The following is a description of a gene set: Mouse Gene Set: ZKSCAN1_TARGET_GENES Genes containing one or more binding sites for (Zkscan1) in their promoter regions (TSS -1000,+100 bp) as identified by GTRD version 20.06 ChIP-seq harmonization. species: Mus musculus from publication Yevshin I, Sharipov R, Kolmykov S, Kondrakhin Y, Kolpakov F (PMID 30445619), and this is the list of marker genes: Cd84, Tsen15, Ly6g, Avil, Fdx2, Slc6a7, Gm26440, Dmtn, Fmnl1, Sema4a, Chmp2a, Lyrm9, Pdzd2, Arl10, Sec22b, Gm7538, Eif4a2, Cog7, Ctnnb1, Slc6a9, Vsir, Bbc3, Slc25a36, Adgrd2-ps, Ubc, Rhod, Adgrl2, Cd300c, Gm31373, Utp14a, Hdac7, Gna15, Cdk2ap1, Kmt2a, Rapgef3, Cilk1, Hspe1, Abhd2, Myo10 (myosin X), Derl3, Ctu2, Zfp579, Ube2f, Ddx39a, Phc1 (polyhomeotic 1), Exoc2, 0610012D04Rik, Aldoa, 3110083C13Rik, Tnfsf12, A430005L14Rik, Tnnt1, Sergef, Atxn2, Ythdf2, Myo15b, Trim14, Zfp458, Dhrs7, Snx12, Arhgap27os1, Tmem25, Nfxl1, Gm19710, Cops8, Frat1, Armt1 (acidic residue methyltransferase 1), Ddx51, Zfp438, Nr1d1, Jup, A930001C03Rik, Ssbp1, Tnpo2, Zfp518a, Cdca5, Cnst, Ap5s1, Tmem63b, Mlip, Psmc1, Adamtsl5, Macroh2a1, Sh3bp1, Ncor2, Plscr1l1, Gm17786, Zfp444, Tmem229b, Ccdc97, Sh3bgrl, Gnb2, Idh2, Ggt1, Cfap97d1, Zfp58, C920009B18Rik, Stab1, Sdf4, Cltc, Nceh1, Vps16, Syde2, Klf1, Ube2l3, Gpam, 2010320O07Rik, Mef2a, Rmnd1, Ibtk, Glo1, Gm12279, Gm24195, Alg9, Psme1, AW495222, Nfatc2, Etv6, Gm10778, Gpr182, Rnf166, Tpcn1, Hif3a, Zbtb7a, Slc25a20, Cldn10, Zdhhc5, Dok2, Tgif2, Pten, Stx6, Yipf1, Phip, Tmem9b, Glud1, Zc3h6, Zan, Ssrp1, Ubb (NCBI Gene Id 22187), Zfp87, Adam22, Slc2a9, Cwc15, Cytip, Bmf, Tomt, Hoxd3, Ccdc88a, 2810013P06Rik, Rpl9, Kit (KIT proto-oncogene receptor tyrosine kinase), Slc19a3, Igf2bp1, Strn4, Sycp2l, Sat1 (NCBI Gene Id 20229), Cd74 (CD74 antigen (invariant polypeptide of major histocompatibility complex, class II antigen-associated)), Ecel1, Noc4l, Mark2, Ralgapb (NCBI Gene Id 99013), Zmynd19, Rfx2, Dnajc15, Gm5960, Ptpn3, Slu7, Spag6 (NCBI Gene Id 381350), Asb1, Wtap, Ino80dos, Tnfsfm13, Ahi1, Otogl, Calm3, Stmp1, Gm17023, Tmem176b, Gm5447, Nr2f1, Scly, Defb30, Unc5b, Chid1, Pms1, Kctd17, Lgals1, Brap, Lias, Kdm5b, Gnat2, Prdm15, Haus5, 4933426K07Rik, Elmo2, Ppp2r3a, Nat10 (NCBI Gene Id 98956), Or2t26, Epn1, Rhbdf1, Irak4, A830082K12Rik, Tram1, Slc41a2 (NCBI Gene Id 338365), Ccng2, Hspd1 (heat shock protein 1 (chaperonin)), Med6, Bahd1, Ogt, Rrp36, Arid1b, Mpz, Iqcf4 (IQ motif containing F4), Ppil4, Gm11523, Gm11175, Unc13a, Slc19a1, Rptor, Mir1932, AU041133, Lypla2, Mrpl27 (mitochondrial ribosomal protein L27), Ugt1a7c, Scp2, Klhdc8b, Noa1, Elavl1, Son, Siae, Mrpl10, Thumpd3, Gnai2, Gm13025, Fscn1, Cd164, Pkp1, Synrg, Kpna3, Tmem176a, Ccn5, Stimate, Necap2, Arhgef6, Ing3, Acot8, Rasgrp4, S1pr2, Mprip, Cttnbp2 (cortactin binding protein 2), 1700029M20Rik, Zfp236, Mcur1, Qsox2, Mia2, Ubr3, Hpdl, 1700020N01Rik, Fnta, Wdtc1, Atg2a, Gm10863, 1810019N24Rik, Lpin1, Sumf2, Susd1, Gigyf2, Cmtm4, Mbtps2, Tpm2, Ncln, Ccdc71, Hax1, Kcnn4, Ak3, Ginm1, Spcs2, Tmco4, Arhgap18 (NCBI Gene Id 73910), Grm2, Bicdl2, Tmem42, Rusc2, Paip1, D8Ertd738e, Plekha7, Rap1a, Emc7, Nhlrc3, Lama4 (laminin, alpha 4), Smurf2, Zfpl1, Mir3089, Rpl41, Gm8790 (NCBI Gene Id 667745), Gm10524, Tbl1xr1, Ccl22, Sh3glb1, Pttg1 (pituitary tumor-transforming gene 1), Slc22a18, Adamts10, Zfp282, Ulk2, Fgd3, Rhof, Dnal4, Tomm20, Adnp, Ly6c2, Zfp513, Dnajc21, Slc2a6, Pbk, Magoh, Ing4, Tatdn2, Itpripl2, Map2k3 (NCBI Gene Id 26397), Gab2, Kri1, Serpinc1, 1700021A07Rik, Csf2ra, Cct8, Tbcc, Snx11, Yars2, Mir3965, Lamtor3, Kdm4d, Eef2k, Nfatc2ip, Nfkb1, Cxcr5, Trnau1ap, Ahsa2, Ptov1, Glipr1, Hinfp (histone H4 transcription factor), 1810044D09Rik, Pde4a, Snapc5, 9230111E07Rik, Mrpl39, Pou2af1, Gm25821, Gm12119, Tex15, Nr1h2, Epo, Gnas (GNAS complex locus), Gm15599, Rapgef4os1 (NCBI Gene Id 100040270), Arhgap23, Fam20a, Gm8066, Them4, Cfap68, Cp, Mir130b, Hus1b, Gm13835, Uba7, Ak1, Mgst3, Rac2, 4930519P11Rik, Itga10, Oxld1, Ppip5k2, Rp9, Slc52a3, Washc3, Fcrla, Ace, Dusp7, Rps15a, Aacs, Gm13655, Unc119, Mir301b, Itpkb, Map2k6, Lrsam1, Tedc2, Khk, Mir8092, Armh3, Atp5f1b, Slc38a3, 5730471H19Rik, Dapk3, Fdxacb1, Tob2, Spa17, Ormdl1, Ado, C630004L07Rik, Tsc2, Sh3tc1, Gna11, Zfp128, Rgsl1, Ephx2, Calm1, Oprl1, Parl, Tbc1d1, Ly6a, Tsc1, Heg1, Hoxd3os1, Lmnb1, Mzb1, Higd1a, Rpl36-ps8, Gm11613, Tcea2, Antxr1, Bcl11a, Arhgef19, Tg, Acyp1, Proser1, Nup153, Fbxo9 (NCBI Gene Id 71538), Hsp90ab1, Snrnp70, Trnt1, Vav1, Zfp809, Hsd17b14, Lsp1, Nup133, Zfp395, Asb6, Mir3064, Sptbn1, Fbxw10, Mtf2, Rgs3, Gm11689, Gsap, Lrrc46, Tpp1, Gm10244, Clcnkb, Zfp746, Gm5857, Mier2, Rnf135, 2210417A02Rik, Heatr9, Kcnk6, Ldlrad4, Dusp3, Plcxd1, Ino80d, Cryba2, Samd15, Tyro3, Pik3r2, Ino80c, Tjp3, Esyt3, Bola2, P4ha2 (procollagen-proline, 2-oxoglutarate 4-dioxygenase (proline 4-hydroxylase), alpha II polypeptide)